The following is a description of a gene set: from publication Haribhai D, Lin W, Edwards B, Ziegelbauer J, Salzman NH, Carlson MR, Li SH, Simpson PM, Chatila TA, Williams CB (PMID 19265124) studied in species Homo sapiens The gene expression profile of peripheral Foxp3+ natural regulatory T cells isolated from Foxp3/EGFP bicistronic mice was compared to that of in vitro-induced regulatory T cells and to CD4+ conventional (Foxp3-) T cells. The role of the regulatory T cell transcription factor Foxp3 in shaping the transcriptosomes of natural and induced regulatory T cells was analyzed using mice expressing a mutant FOXP3-EGFP fusion protein (Foxp3deltaEGFP). We used gene expression microarrays to examine the transcriptional programs of natural and induced regulatory T cells and the function of Foxp3 in organizing the transcriptosomes of the respective cell type Human Gene Set: GSE14415_INDUCED_TREG_VS_TCONV_UP Genes up-regulated in induced T reg versus T conv., and this is the list of marker genes: H2BC26, EPAS1, CEP72, RANBP1, BUB1, CCNA2, RIPK3, HADH, POLQ, PPIL1, ZBP1, SHMT1, PTMS, ANXA2, SPC24, CLIC1, PSMA1, RRM2, VIM, SERPINE2, CENPP, DSCC1, LSM12, GMNN, TMEM67, NUDT1, SGO1, GLTP, SPAG5, ROM1, TPI1, MCM10, ARHGAP21, CENPS, TKT, NDC1, FAM72A, DDOST, HAT1, CDC20, RCC1, SURF4, E2F7 (NCBI Gene Id 144455), KIF22, NEIL3, POLL, CDC123, SPDL1, SC5D, MXD3, H2BC1, BIRC5, NRM (NCBI Gene Id 11270), TTC9C, DPAGT1, TRIP13, UBE2L3, FBXO5, H2BC9, TRAIP, RAD51, HAVCR2, CS, ERP29 (NCBI Gene Id 10961), KIF18B, CCNB2, TAF12, GET3, JPT2, CDC14A, LAMP2, PLXNB2, SNX9, PSMA5, CDK1, GEN1, MAD2L1 (NCBI Gene Id 4085), PSAT1, LSM2, WIZ, PIGT, ARSB, DCK, LRR1, CDC45, CKS1B, UBE2I, LSM3, LY6E, SHMT2, H1-1, COPS5, ACP1 (NCBI Gene Id 52), CDCA8, TFDP1, DBI, CDCA3, DDX39A, RBBP7 (NCBI Gene Id 5931), GZMB, TAGLN2, CDK2AP1, POLR3K, H2BC3 (H2B clustered histone 3), AURKB, TUBGCP2, PSMD3, NUF2, GZMK, H4C8, NHP2, GGT1, CENPN, NME1, CDC25B, NUP37, PRIM1, SNRPA, RAN, RPS6KA1, AP2A2, SPC25, KNL1 (NCBI Gene Id 57082), FIGNL1, PYCARD, PBK, HEATR3, CALM1, PHGDH, SLC25A13, MCM7, DUT, CALM3, PCBP1, CHTF18, PMM1, KIF15, RFC3, RAD51AP1, LGALS1, CDKN2C, H4C14, HAUS1, ZBTB32, ASF1B, CDC25C, PRIM2, RPA3, ATP5IF1, CDKN3, STMN1, PLK1, HMMR, CKAP2L, MYL4, TUBB4B, IMPA2, MKI67, ETFB, BUB3, SNRPA1, PSMC3IP, MTX1, TROAP, RFC5, SDHD, PSMB2, GINS1, H2AC15, MRPL18, IRF8, SCARB1, ADAP1, AURKA, HIRIP3, POLE2, SYCE2, BARD1, MIS18BP1